The following is a description of a gene set: Mouse Gene Set: GOMF_HYDROLASE_ACTIVITY_HYDROLYZING_N_GLYCOSYL_COMPOUNDS studied in species Mus musculus Catalysis of the hydrolysis of any N-glycosyl bond., and this is the list of marker genes: Smug1, Tlr11, Sarm1, Neil2, Dnph1, Art2a, Il1rl2, Tdg-ps, Mutyh, Neil1, Il18r1, Mbd4, Macrod2, Nthl1, Bst1, Il1rl1, Dctd, Ogg1, Pcna, Il18rap, Tlr1, Adprh, Il1rapl1, Il1rapl2, Man2a1, Il1rap, Tlr6, Neil3, Adprs, Tlr4, Macrod1, Mpg, Cd38, Oard1, Man2a2, Tlr12, Tlr2, Tdg, Il1r1, Art2b, Tlr13, Adprhl1, Ung